The following is a description of a gene set: Mouse Gene Set: chr2D studied in species Mus musculus, and this is the list of marker genes: Olfr1041-ps1, Or5m3, Or5al1, Or8h11-ps1, Or12e11-ps1, Or9b1-ps1, Or8k39, Or5j1, Or8k38, Or8z1-ps1, Gm24037, Or9g4, Or5d41, Gm23716, Gm13720, Or8y1-ps1, Gm5023, Or4c102, Or5m13, A130030D18Rik, Or8u8, Or9g21-ps, Or4c31, Or8j3c, Or5be3, Or12e8, Or8k24, Or8k17, Fsip2 (NCBI Gene Id 637858), Gm13730, Or8k36-ps1, Or5g27, Cwc22rt1, Or8k35, Gm13728, Dnmt3l-ps1, Or5ak22, Or10ag60, Or4c99, Or5w1b, Or8h6, Or5ap2b-ps1, Or5g28-ps1, Or5d35, Or5t16, Gm20734, Or8i2, Gm13735, Or2ah1, Or5al6, Or5n1-ps1, Or5m9, Olfr1007-ps1, Gm13736, Or5m11, Or5aq7, Gm13679, Or5w10, Or5w19, Or10ag54, Or10ag59, Tnks1bp1, Or10e1-ps1, Or12e16-ps1, Gm13683, Gm13742, Or5m11d-ps1, Or5d47 (olfactory receptor family 5 subfamily D member 47), Or5m8, Or12e14, Gm13675, Or5d36, Pramel6, Or5d16, Or5t15, Or8j3b, Or5m10, Or10ag52 (NCBI Gene Id 404327), Or5d18, Or5m5, Or8k53, Prg2, Or5av1-ps1, Or5m10b, Or5aj1-ps1, Olfr1108-ps1, Or5d37, Ypel4, Or5ai1-ps1, Or5w9-ps1, Or4p19, Cwc22rt5, Or5j3, Or4p4, Or4p18, Cwc22rt3, Or9b2-ps1, Or12e10, Or5d14, Gm13712, Gm19426, Or8k40, Or9g4b, Zc3h15, Zfp804a, Or9c1-ps1, Or8k22, Ctnnd1, Or10ag57, Or5aq1b, Olfr1172-ps1, Or8k30, Or5w8, Or8k37 (NCBI Gene Id 258235), Or5d43, Gm13758, Or8k20, Or5ak21-ps1, Or4c103, Or5al7, Or8w1, Or8u9, Med19, Or5m11b, Or5g26, Or10ag53, Gm13680, Fam171b, Or8k1d-ps1, Or5t7, Gm13733 (NCBI Gene Id 668402), Cwc22rt6, Gm13744, Calcrl, Mir130a, Or4p22, Slc43a1, Clp1, Or5w17, Or5ak25, Or5w13, Gm13676, Or5ak23, Tmx2, Or5w15, Or8u3-ps, Or8k41, Serping1, Or5ar1, Or10ag58, Or8aa1-ps1, Or8k32, Or8k18, Or8k34-ps1, Aplnr, Or8k29-ps1, Gm40020, Or4s2b, Gm1826, Or8k26-ps1, Gm13745, Or9g20, Or8u10, Or12e13, Or5g30-ps1, Lrrc55 (leucine rich repeat containing 55), Cwc22rt4 (NCBI Gene Id 668107), Olfr1060-ps1, Or9m1b, Gm13682, Or5t18, Or12e12-ps1, Or5i1, Or8k3, Or5l13, Or8k3b, Or8k1, Or9g8, Or4a66, Or8k42-ps1, Or12e9, Gm13740, Or5aq1, Or5w16, Lrrc55os, Or5g29 (olfactory receptor family 5 subfamily G member 29), Or8k25, Cwc22rt7, Or5w11, Or4p7, Or9g19, Or5d42-ps1, Smtnl1, Or5g23, Or12e15-ps1, Or9m1, Or5d38, Or8h8, Or5w20, Ssrp1, Or5m9b, Or10ag55-ps1, Or5as1, Selenoh, Or8y2-ps1, Or5m3b, Or5w21-ps1, Gm13702, 4930443O20Rik, Or5g24-ps1, Gm13729, Gm13715, Or4c100, Gm13743, Or5t17, Btbd18, Or9g3, Zswim2, Or12a1-ps1, Or8k21, Fads2b, Or5m13b, Or4s2, Pramel7, Or5d40, Or8e1-ps1, Or4p21, Or5d45, Or5aq6, Or10ag56, Or4c101, Or9m2, Or5d46, Or10ag2, Tfpi, Or5g9, Prg3, Or8k16, Or8h10, Or8j3, Gm13732, Or8k28, Nlk-ps1 (nemo like kinase, pseudogene 1), Timm10, Or5w18, Itgav, Gm13719, Or9g10, Or8h7, Or5m12, Or5t5, P2rx3, Or5w14, Gm13738, Or8h9, Ube2l6, Gm13722, Or5ak24, Rtn4rl2, Slc43a3, Or4p4b-ps1 (NCBI Gene Id 404395), Or5g25, Gm13677, Or5w12, Gm13710, Or4ac1-ps1, Cwc22rt2, Or5l14, Or5al5, Or5ak4, Olfr1169-ps1 (olfactory receptor 1169, pseudogene 1), Or5ak20, Or5ap2, Or5d20-ps1, Or8k27, Or8m1-ps1, Or5t9, Or4p20, Or8u37-ps1, Or8k33, Or5w22, Olfr1139-ps1, Or5d3, Or5d44, Gm13714, Or12e7, Or5w1, Or8k31-ps1, Or8z2-ps1, Or5d39, Or12e1, Zdhhc5, Or8k23